The following is a description of a gene set: Human Gene Set: GOBP_NEGATIVE_REGULATION_OF_INTRINSIC_APOPTOTIC_SIGNALING_PATHWAY_IN_RESPONSE_TO_OSMOTIC_STRESS Any process that stops, prevents or reduces the frequency, rate or extent of intrinsic apoptotic signaling pathway in response to osmotic stress. studied in species Homo sapiens, and this is the list of marker genes: YBX3, PTGS2, EPO, ARHGEF2, BDKRB2